The following is a description of a gene set: Genes predicted to be targets of miRBase v22 microRNA hsa-miR-34b-3p in miRDB v6.0 with MirTarget v4 prediction scores > 80 (high confidence targets). species: Homo sapiens from publication Chen Y, Wang X (PMID 31504780) Human Gene Set: MIR34B_3P, and this is the list of marker genes: ZBTB44, GPATCH8, GBP4, RCN2, ABI2, TAF5, LY75-CD302, GPR137C, CLOCK, KIF2A, YY1, CAPZA1, PDK1, MEST, MYCT1, BRINP2, CASK, TRAF3, NAF1, TIA1, PTPRE (protein tyrosine phosphatase receptor type E), EEIG2, UBE2N (ubiquitin conjugating enzyme E2 N), FURIN, SLC9A6, DHX15, ZNF268, TM9SF3, OSTC, TENM1, MCM9, DTNA, ZNF879, CAMK4, CD302, MARCHF4, YWHAG, CLINT1, TNPO1 (NCBI Gene Id 3842), MRAS, NEPRO (NCBI Gene Id 285338), FDX1, MIA2, PCDH17, NPTN, MRPL19, MYSM1, TMOD1, HSF5, NCOA4, RPRD1A, STX3, NUP50, BROX, ZNF367, FNDC3A, TBRG1, NCAPG2, PIGN, PRKAR2B, MBD5, SNAP23, RPE, SF3B1, TLNRD1 (NCBI Gene Id 59274), DYNLT5, HHEX, DCUN1D4, CAB39L, RYBP, BTBD7, PSME4, ATP8A2, F2RL2, MTF2, G2E3, ZNF84, ZFP82, L3HYPDH, CCK, ESPL1, NCKAP1, GCNT1 (NCBI Gene Id 2650), CELF2, ZNF449, PPP6R3, YTHDC2, BNIP3L, CPEB3, PDGFA, GUCY1A2, PGRMC1, WBP2NL (WBP2 N-terminal like), SETD3, LRRC31, ZNF71 (zinc finger protein 71), SLITRK3, TTC9, SLC39A9 (NCBI Gene Id 55334), INSIG1, LIN54, TENT4B, SERPINF2, MAP2 (microtubule associated protein 2), AKTIP, CTAGE1, ITM2B, RTKN2 (NCBI Gene Id 254060), AGO3, NUP42, GABRB2